Given this list of marker genes FLT4, PIEZO1, CARD14, LBR, CD28, TNFRSF1B, HLA-DRA (NCBI Gene Id 7930), KRT10, CTLA4, GJC2, COL7A1, OSMR, NTRK1, ANGPT2, CSTA, here is a description of the gene set: Lichenification Thickening and hardening of the epidermis seen with exaggeration of normal skin lines. species: Homo sapiens Human Gene Set: HP_LICHENIFICATION